The following is a description of a gene set: Genes predicted to be targets of miRBase v22 microRNA hsa-miR-92b-5p in miRDB v6.0 with MirTarget v4 prediction scores > 80 (high confidence targets). studied in species Homo sapiens Human Gene Set: MIR92B_5P from publication Chen Y, Wang X (PMID 31504780), and this is the list of marker genes: KNOP1, SLC7A5, PPP2R2D, AGO2, FN3K, RABGEF1, CRTC1, ID1